The following is a description of a gene set: species: Mus musculus Mouse Gene Set: GOBP_SMAD_PROTEIN_SIGNAL_TRANSDUCTION An intracellular signaling cassette that starts with the activation of a SMAD protein, leading to the formation of a complex with co-SMADs, which translocates to the nucleus and regulates transcription of specific target genes., and this is the list of marker genes: Atoh8, Smad9, Bmper, Pin1rt1, Wwtr1, Zmiz1, Tgfb3, Nodal, Mapk8, Mir744, Gdf5, Inhba (inhibin beta-A), Nup93, Dab2, Twsg1, Bmp6, Mir181c, Pmepa1, Bmp10, Dkk1, Ski (NCBI Gene Id 99956), Bmpr1a (NCBI Gene Id 68748), Acvrl1, Mir25, Hipk2, Pin1, Bmp2, Grem1, Smad6, Ldlrad4, Parp1, Gdf15, Fos, Tgfb1, Lrp1, Ccn3, Bmp7, Jak2, Smad2, Mir181d (microRNA 181d), Mir185, Lgals9, Runx2, Becn1, Tgfbr3, Tgfbr2, Smad1, Smad7, Gdf7, Jun, Xbp1, Mir382, Acvr2a, Sh2b1, Pml, Ovol2, Smad4, Gdf6, Emilin1, Cilp, Acvr1, Glce, Gdf11 (NCBI Gene Id 14561), Pparg, Cited1 (NCBI Gene Id 12705), Tgfbr1, Fam89b (family with sequence similarity 89, member B), Mir7-1, Mir290a, Eng, Tob1, Ror2, Bmp4, Gdf2, D130043K22Rik, Amh, Veph1, Csnk2b, Map1lc3a, Magi2, Ucma, Smad3, Rbpms, Tgfb2, Mir130a, Bmpr2, Eid2, Sptbn1, Bmp5, Nog, Tbx20, Smad5, Hfe, Mir7-2